Given this list of marker genes TNFRSF25, ICMT (NCBI Gene Id 57087), HES3, THAP3, PLEKHG5, ZBTB48, ACOT7, DNAJC11, KCNAB2, RNF207 (NCBI Gene Id 388591), HES2, NOL9, CAMTA1, AJAP1, PHF13, GPR153, CHD5, NPHP4, ESPN, TAS1R1, KLHL21, RPL22, here is a description of the gene set: Neuroblastomas are characterized by 1p deletions, suggesting that a tumor suppressor gene (TSG) resides in this region. We have mapped the smallest region of deletion (SRD) to a 2 Mb region of 1p36.31 using microsatellite and single nucleotide polymorphisms. We have identified genes in this region, and we have analysed these genes for mutations and RNA expression patterns to identify candidate TSGs. We sequenced the coding exons of these genes in 30 neuroblastoma cell lines. Although rare mutations were found in 10 of the genes, none showed a pattern of genetic change consistent with homozygous inactivation. We examined the expression of these genes in 20 neuroblastoma cell lines, and most showed readily detectable expression, and no correlation with 1p deletion. However, genes showed uniformly low expression in the lines, and genes (CHD5, RNF207) had virtually absent expression, consistent with the expected pattern for a TSG. Our mutation and expression analysis in neuroblastoma cell lines, combined with expression analysis in normal tissues, putative function and prior implication in neuroblastoma pathogenesis, suggests that the most promising TSG deleted from the 1p36 SRD is CHD5, but TNFRSF25, CAMTA1 and AJAP1 are also viable candidates. Genes in the smallest region of deletion (SRD) in 1p36.3 area in neuroblastoma samples. Human Gene Set: OKAWA_NEUROBLASTOMA_1P36_31_DELETION from publication Okawa ER, Gotoh T, Manne J, Igarashi J, Fujita T, Silverman KA, Xhao H, Mosse YP, White PS, Brodeur GM (PMID 17667943) studied in species Homo sapiens